The following is a description of a gene set: Mouse Gene Set: MIR_470_3P Genes predicted to be targets of miRBase v22 microRNA mmu_miR_470_3p in miRDB v6.0 with MirTarget v4 prediction scores > 80 (high confidence targets). studied in species Mus musculus from publication Chen Y, Wang X (PMID 31504780), and this is the list of marker genes: Klb, Crb1, Atp6v1e1, Kat2b, Tbx5, Arpc2, Slc18a2, Prrg1, Hspd1, Fam135a, Rap1gds1, Usp9x, Birc6 (baculoviral IAP repeat-containing 6), Fam107a, Cnr1, Asph, Cbx2, Tead1, Nptx1, Wee1, Sh3d19, Sort1, Col9a1, Gja1, Lamp2, Cnksr2, Ttpal, Ufm1, Rps20, Rnf180, Mindy3, Rdh14, Pbx1, Cept1 (choline/ethanolaminephosphotransferase 1), Suz12, Arl8b, Cpsf6, Slc38a4, Speer4a1, Slc25a36, Derl1, Zfp280b, Ccz1, Kpna1 (NCBI Gene Id 16646), Dapk1, Alyref, Nr3c1, Gadd45a, Ireb2 (iron responsive element binding protein 2), Ash1l, Atad2 (ATPase family, AAA domain containing 2), Frem2